Given this list of marker genes Gm4287, 1600020E01Rik, 4930402H05Rik, Gkn1, Vmn1r49, Vmn1r-ps34, Vmn1r-ps26, Vmn1r48, Pcyox1 (NCBI Gene Id 66881), 4930517G19Rik (NCBI Gene Id 74727), Dnajb8, Nr2c2, Tmem43, Hdac11, Gm44064, 9530026P05Rik, Gm23035, Gm19908, Gm7825, Isy1, Vmn1r-ps25, Adamts9, Anxa4, Gm5313, Vmn1r54, Kbtbd12, Vmn1r42, Gm30437, 1810044D09Rik, Uroc1, Gm20426, Tpra1, Wnt7a, E230015B07Rik, Rab43, Snrpg, Vmn1r52, 1700031F10Rik, Vmn1r51, Aldh1l1, Gm22312, Aplf, Fbln2, Gm10443, Gm22840, Mir6376, Gm25185, Rab7, Slc41a3, Gm44981, Ccdc174, Rpl21-ps12, 2610306M01Rik, Chst13, Podxl2, Grip2, Chchd6, Gm5577, V1ra8, Rbsn, Gm44097, Snrnp27, A730049H05Rik, Gm1965, Mxd1, Lsm3, Copg1, Slc6a6, Bmp10, Vmn1r-ps27, Ruvbl1, Efcc1, D6Ertd527e, Spehd, Vmn1r-ps32, Arhgap25, Gm7812, Rpn1, Xpc, Gkn3, 4933427D06Rik, Cfap100, Gm4575, Nup210, Gm839, Gm44803, Cnbp, 9930120I10Rik, Gm44264, 4933412L11Rik, Vmn1r43, A430078I02Rik, H1f10, Asprv1, Vmn1r44, Gp9, Vmn1r40, Magi1, Prokr1, Gm5879, Cfap92, Rps19-ps9, Vmn1r-ps29 (vomeronasal 1 receptor, pseudogene 29), Ppp1r2-ps2, 4930590J08Rik, Sec61a1, Gm36189, Aak1, Pcbp1, Vmn1r47, Gm34312, C030015A19Rik, Gm15612, Klf15, Zxdc, Nfu1, C87436, Txnrd3, BC048671 (cDNA sequence BC048671), Chchd4, Abtb1 (ankyrin repeat and BTB domain containing 1), Hmces, Vmn1r-ps28, Gm6507, 4930466I24Rik, Gm15756, Gm19596, Mcm2, Eefsec, B130021K23Rik, Vmn1r-ps31, Gm18862, Tgfa (transforming growth factor alpha), Fgd5, Gm15737, Mrps25, Gm7545, Gm17797, Fam136a, 2310040G24Rik, Vmn1r46, 4930512J16Rik, Vmn1r50, Gata2, Iqsec1, Gmcl1, Vmn1r53, Gm26588, Antxr1, Tia1, Prickle2, Trh, Plxna1, 9530013L04Rik, Mgll, Vmn1r41, Gm25094, Gkn2, Gfpt1, Vmn1r45, here is a description of the gene set: Mouse Gene Set: chr6D1 studied in species Mus musculus